Given this list of marker genes Mcee, Hadha, Dbi, Acot7, Them4, Decr1, Acot2, Eci1, Acadvl, Acbd7, Acot3, Acbd6, Mecr, Acad10, Acot13, Acsf2, Acot5, here is a description of the gene set: This event has been computationally inferred from an event that has been demonstrated in another species.<p>The inference is based on the homology mapping from PANTHER. Briefly, reactions for which all involved PhysicalEntities (in input, output and catalyst) have a mapped orthologue/paralogue (for complexes at least 75% of components must have a mapping) are inferred to the other species. electronically inferred by orthology from the curated human pathway part of: Fatty acid metabolism studied in species Mus musculus Reactome Pathway: Mitochondrial Fatty Acid Beta-Oxidation